Given this list of marker genes Tub, Spata7, Zdhhc3, Rom1, Bbs4, Pcare, Tulp1, here is a description of the gene set: A process in which a protein is transported to, or maintained in, a location within a photoreceptor outer segment. Mouse Gene Set: GOBP_PROTEIN_LOCALIZATION_TO_PHOTORECEPTOR_OUTER_SEGMENT species: Mus musculus